Given this list of marker genes HTR6, ADRA2A, ADRB1, HTR5A, HTR2A, TAAR3P, ADRB3, TAAR8, TAAR5, ADRA1D, ADRA2B, TAAR1, HRH4, CHRM5, HRH1, DRD4, CHRM3, GPR88, ADRA1A (NCBI Gene Id 148), HTR2C, HTR1E, ADRB2, ADRA2C, HTR1F, HTR2B, CHRM2, HTR1B, TAAR6, ZNF219, HTR4, HTR1A, HRH2, TAAR9, ADRA1B, CHRM1, OR5AN1 (olfactory receptor family 5 subfamily AN member 1), HTR1D, TAAR2, HTR7, HRH3, CHRM4, here is a description of the gene set: studied in species Homo sapiens Combining with an extracellular amine and transmitting the signal across the membrane by activating an associated G-protein; promotes the exchange of GDP for GTP on the alpha subunit of a heterotrimeric G-protein complex. Human Gene Set: GOMF_G_PROTEIN_COUPLED_AMINE_RECEPTOR_ACTIVITY